Given this list of marker genes PKM, GPT, TPI1, GAPDH, PGAM2, PFKM (phosphofructokinase, muscle), ALDOA, GPI, LDHA, ENO1, SLC2A1, PGK1, HK1, here is a description of the gene set: Aerobic glycolysis - augmented Human Gene Set: WP_AEROBIC_GLYCOLYSIS_AUGMENTED species: Homo sapiens